The following is a description of a gene set: species: Homo sapiens The aggregation, arrangement and bonding together of a set of components to form a cornified envelope. Human Gene Set: GOBP_CORNIFIED_ENVELOPE_ASSEMBLY, and this is the list of marker genes: UGCG, STX4, DMKN, STX2, MAFB, HDAC3